The following is a description of a gene set: Genes down-regulated in CD4 T cells: untreated versus TGFB1. studied in species Homo sapiens Human Gene Set: GSE22025_UNTREATED_VS_TGFB1_TREATED_CD4_TCELL_DN We examined the global gene expression pattern of T cells regulated by progesterone to gain further insights into the regulatory mechanisms of progesterone. We found 325-347 cord blood T cell genes up or down-regulated by P4 in the presence or absence of exogenous TGFb1. Peripheral blood T cells were relatively unresponsive with only 30-genes regulated by P4. IL-6 receptor (IL-6R) expression was greatly down-regulated by progesterone in cord blood, but not PB, T cells. Overall, these differences in gene expression are consistent with the differential responses of cord blood and peripheral blood T cells to progesterone. To gain insights into the differences of progesterone and control dendritic cells, we performed a microarray study and found ~genes regulated by progesterone in dendritic cells. The gene expression information suggests that progesterone has the potential to alter dendritic cell responses to cytokines, chemokine production, and migration which in combination would control T cell differentiation. from publication Lee JH, Ulrich B, Cho J, Park J, Kim CH (PMID 21768398), and this is the list of marker genes: PART1, ITGAX, MTCL1, ATP8B1, EGF, SCN5A, SOD3, DDN, CAMP, ATF6B, ACACB (NCBI Gene Id 32), ITGB7, CCL2, SPATA2L, TIMELESS, ASTN2, MT4, NPY5R, ANPEP, HTR1B, GZMH, CXCL2, CYP3A5, PSMB8, BTBD8, STK35, PTK2B, GSTA2, SOAT2, CD72, SLC27A2, GLI1, AFDN, JAK2, ZNF133, GBP2, NDN, LY9, HAS1, SERPINB2, LPAR2, AFF3, PML, PLEKHA6, RAD51C, TTN, CACNG1, NHLH1, DNA2, DSCR4, SYN1, DBP, HOXD13, ADGRE5, PHACTR1, LAIR1, NPAS3, ST3GAL1, STC1, SPOCK1, HMCES (5-hydroxymethylcytosine binding, ES cell specific), LIPE (NCBI Gene Id 3991), PCBD1, ESYT1, SEMA4F, MAP2, ICOSLG, ITGA9, DHRS3, HLA-DMA, SAMD14, SCNN1G, BST2, APOBEC3B, PCOLCE, KIR3DL1, SLC12A4, DNAH3, ZNF75D, TGOLN2, ST3GAL2 (NCBI Gene Id 729518), MLF1, SGSM3, RBBP5, DOC2B, CD27, IQCE, TTLL4, MARCHF2, PRELID3A, AGPAT1, CEMIP, CTNNAL1, OVOL3, HOXC11, CDC42EP1, SLC9A7, EDNRB, CCN5, DLK1, KCNJ10, INHBA, CELA2A, FAM53B, TLR6, ACHE, PIR, SNUPN, GPR20, TMOD1, ZCCHC24, HCN2, LPAR4, FPGT, AGAP1, RLBP1, NDUFB8, NAGLU, ANXA9, CEL, ZFP69B, ZNF80, SLC6A6, MTERF1, BIRC5, MMP19, RGS12, ANXA6, CUX1, MDFIC, CPS1, REEP2, RND1, KCNJ9, AP2A2, KIF1C, CDC14B, B3GNTL1, IGSF9B, SMCP, NELL1, RCAN2, HMHB1, IRF9, RANBP6, NLRP1, CREBZF, GRK3 (G protein-coupled receptor kinase 3), ID3, EPS8, PTGER1, PAFAH2, VIP, EPHB6 (EPH receptor B6), PTPRU, THRA, EPN2, RING1, KLKB1, FETUB, KRT33A, NEUROD2, SPOCK2, PBX2, ARB2A, MAGEC1, EML2 (NCBI Gene Id 24139), PRSS53, CDH8, CMA1, TPST2, KRT83, GUCA1B, KRTAP5-9, TCTA, ZWINT, CDH22, MYO10, POU2AF1, PRKD2, GATA2, NTSR1, METTL3, PRCP, CYP21A2, FGFBP1 (NCBI Gene Id 9982), WDR77, EMID1, NAT8, OR5I1, UTF1, SCNN1A, ZNF177, SPA17, GPA33, COX20, ARHGEF5, CCDC9, TFF3